The following is a description of a gene set: Human Gene Set: HP_LARYNGOTRACHEAL_STENOSIS Laryngotracheal stenosis studied in species Homo sapiens, and this is the list of marker genes: SLC26A2, SMAD4, ADAMTSL2, FLNB, EXTL3